The following is a description of a gene set: from publication Cui Y, Zheng Y, Liu X, Yan L, Fan X, Yong J, Hu Y, Dong J, Li Q, Wu X, Gao S, Li J, Wen L, Qiao J, Tang F (PMID 30759401) studied in species Homo sapiens Human Gene Set: CUI_DEVELOPING_HEART_CORONARY_VASCULAR_ENDOTHELIAL_CELL, and this is the list of marker genes: VWF, COL4A1, MEOX1, DST, APLNR, APOD, ARHGAP18, IGFBP7, GIMAP4, CD36, CD74, RBP7, ADGRL4, FLT4, TM4SF18, MTSS1, ROBO4, TCF4, C1QTNF9, CA4, GMFG, UACA, ITGA6, TNNT3, CLDN5, GIMAP7, A2M, FABP5, HLA-B, TCIM, DIPK2B, FABP4, JAM2, MEF2C, COL15A1, CAV1, RGCC, UTRN, CAVIN2, PDGFB, COL4A2